The following is a description of a gene set: The directed movement of cholesterol into a cell or organelle. Human Gene Set: GOBP_CHOLESTEROL_IMPORT species: Homo sapiens, and this is the list of marker genes: ADIPOQ, CD36, SCARB1, LDLR (NCBI Gene Id 3949), COMMD1, APOA1, APOA2, LAMTOR1 (NCBI Gene Id 55004), STARD4, STARD5, APOC3